Given this list of marker genes APCS, LOXL3, ATG9A, MIR140, HAVCR2, SLC4A2, IL13RA2, CEBPB, YPEL4, DPP4, GRN, CD200R1, SPN, IL33, FBXW7, LILRB3, SAMHD1, LGALS3, SERPING1, RUNX3, PRKAR1A, SFTPD, UBASH3A, LAX1, SCRIB, CRK, GLI3, MEFV, MYC, THY1, EMILIN1, LST1, C4BPA, TARM1, CXCL12, INHBA, HLA-E, CSNK1A1, BPI, HSPA8, PPT1, SLAMF1, TLR6, HOXA7, NCK1, TREX1, IL20RB, ABHD8, HFE, AURKB, ILDR2, RNF125, STAT6, DCST1, IHH, PLCL2, SNAI2, FCGR2B, MAPK3, NRARP, NR1D1, ZNF675, KLRD1, MIR130A, MIR149, BTNL2, TNFRSF21, DLG1 (discs large MAGUK scaffold protein 1), CD160, OTOP1, LGALS9B, TRIM32, CCL21, TSC22D3, HSPA9, SERPINB4, ABHD17A, MFHAS1, CD37, MIR17, AKT1, GREM1, FYN, IRF1, GPX1, TRIM21, PRKDC, IL12B, PLA2G2A, TSC22D1, CEBPA, C5, GRB2, LILRB4, HLA-A, ASCL2, DDT, UFD1, PARP1, CD300LF, BPIFB1 (NCBI Gene Id 92747), GPR17, MMP28, PKN1 (NCBI Gene Id 5585), CX3CR1, NPY, SMCR8, TSPAN6, PRNP, SPI1, RNF115, CD46, NLRC3, LGALS9C, NECTIN2, NECTIN4, PTGER4, APOD (NCBI Gene Id 347), RASSF5, GPR108, CCL2, PLK2, PARP14, MIR19B1, DTX1, HCK, RUNX1, APPL1, HLX, TGFB3, ACOD1, ARG1, USP18, PAG1, FBXO7, CD55, DUSP3, PADI2, BMP5, BANK1, NDFIP1, PPP6C, AMBP, CCL3, CD200, ZDHHC12, LAPTM5, WASL, IAPP, RNF39, ERBIN, SEC14L1, HMGB1, SELENOS (NCBI Gene Id 55829), ERBB2, LGALS9, SFRP1, ADIPOQ, LRRC17, RPS19, FGR, MDK, VSIG4 (NCBI Gene Id 11326), ZC3H8, ITPRIPL1 (ITPRIP like 1), PELI1, CASP3, GPR18, DLL1, IDO1 (indoleamine 2,3-dioxygenase 1), SLIT2, RAG2, MIR185, SOCS5, COL3A1, STAP1, GNRH1, LRFN5, GAL, OLFM4, LRRC32, DAPL1, TIGIT, IFNB1, TTLL12, TNFRSF11B, BMP4, MIF, TYROBP, CUL4A, MIR486-1, SH2D1A, IL2RA, TREM2, STAT5A (NCBI Gene Id 6776), AXL, DHX58, MIR19A (NCBI Gene Id 406979), RHBDD3 (NCBI Gene Id 25807), HLA-B, TICAM2, A2M, FGL1, GPR68, GPS2, NPY5R, TRIB1, C5AR2, LDLR, PTPN2, ERFE, LPXN, IRAK3, RIPOR2, LILRB1, MIA3, MIR27A (microRNA 27a), SYK (spleen associated tyrosine kinase), CPTP, CSK, CR1, SQSTM1, CD300A, PRDX2, SLAMF8, PIAS3, IL4I1, IL10, TGFB1, AHR (NCBI Gene Id 196), MIR222, PAWR, PLA2G2F, CD33, C9orf72, CNR2, STAT2, PSMA1, MIR302A, CUEDC2, DUSP1, MAFB, TMEM176A, CCL25, TMEM176B, RIOK3, ACP5, TBC1D10C, CLNK, SMAD7, ZC3H12A, BCL6, LYPLAL1, PYDC5, GATA2, TGFB2, SMPDL3A, RHBDF2, BTRC, KLRK1, PVR, HLA-G, SOX11, GPNMB, GPR137B, FCRL3, GCSAM, SLA2, BST2, MIR125B1, GPR137, NMI, KITLG, MIR181B1, LAG3, TMEM131L, MIR210, NCKAP1L, MIR6869, MIR181C, KLRC4-KLRK1 (KLRC4-KLRK1 readthrough), TNFAIP6, PYDC2, LTF, FBXL2, DDX39A, TAOK3, ITCH, CTLA4, HMGB3, ADA, ISG15, PYDC1, MNDA, FGL2, SPINK5, GBP1, AARS2, CD68, PCBP2, FER, CD96, LAMP2, IL31RA, TWSG1, MIR708, TRIM31, SIRT2, CD84, RAB7B, DNAJA3, TKFC, PDPK1, MILR1, PGLYRP1, CX3CL1, CR1L, NF1, PLCB1, GDF15, MIR105-1, UBQLN1, NLRC5 (NLR family CARD domain containing 5), PDCD1LG2, CNN2, HLA-DOA, OAS1, SOCS1, PSMB4, CDK6, FCER1G, MAPK14, DTX4, NLRP4, DRD2, DUSP22, TNFSF18, TNFAIP8L2, TNF, HMOX1, GPR55, BTLA, MIR24-1, PPARG, LILRA2, IFNA2, C4BPB, HLA-F, YES1, JAK3, IL4R, PTPRC, INHA, PRDM16, EIF4E2, SFN, ATG12, CD69, CD86, CEACAM1, IL7R, PIM1, CLDN18, NLRX1, ZDHHC18, CCN3, FN1, RIN3, ZBTB46, IL17D, VSIR, CD72, NLRP2B, IL2, CGAS, LRCH1, MIR20A, TAFA3, CD74 (NCBI Gene Id 972), FBN1, HLA-DRB1, WDR41, MIR146A, FAM76B, PPP3CB, TWIST1, SAMSN1 (SAM domain, SH3 domain and nuclear localization signals 1), MIR125A, DGKZ, CEP63, CNOT7, ATG5, PLA2G5, ADAR, SERPINB9, DAB2IP, CD80, IFI16, GNAS, TCTA, TLR4 (NCBI Gene Id 7099), MIR30B, CBFB, PLA2G2D, IFNL1, TMEM178A, TBX21, NR1H2, CD274, ADORA1, USP15, CBLB, CR2, MICOS10-NBL1 (NCBI Gene Id 100532736), TRAFD1, BTK, EPX, SUSD4, BCR, MARCHF5, ARG2, TRIM11, ZFPM1, NBL1, SOX9, DUSP10, KLRC1, OGT, ARRB2, INPP5D, CALCA, GIGYF2 (GRB10 interacting GYF protein 2), SYT11, ANGPT1 (NCBI Gene Id 284), LRRC14, ATM, CYP19A1, ALOX15 (arachidonate 15-lipoxygenase), ANXA1, LILRA4, MIR34A, ADGRF5, IL4, APOA2, MUL1, MAD1L1, PTPN11, PGLYRP3, CCL28, MARCHF7, MMP12, MIR21, INS (insulin), UFL1, FOXJ1, MKRN2, FCRLB (NCBI Gene Id 127943), CARD8, LYN, DLG5, VTCN1, IRF4, SRC, CLEC4G, RARA, PARP3, MIR223, NPLOC4, USP5, MIR200C, GLMN, TAPBPL, YTHDF2, FAM3A, PIK3R1 (NCBI Gene Id 5295), HLA-DOB, TNFSF4, PGLYRP2, FSTL3, TNFRSF14, PRG2, PLCG1, YWHAZ, SARM1, CDKN2A, CD22, CD59, IL27RA, LYAR, ZPBP2, TAX1BP1, TMBIM6, EZR, NLRP6, FOXP3, CLEC12A, KIR2DL4, ADORA2A, CTNNB1, TYRO3, ELF1, PVRIG, GPAM, PTPRS, PDCD1, SHH, MASP1, GRAMD4, TARBP2, F2RL1, TNFRSF13B, GPATCH3, SDC4, CTSG, ADTRP, CCR2, RC3H1, XCL1, LILRB2, SMPDL3B, MERTK, RABGEF1, SPSB3 (NCBI Gene Id 90864), TRIM27, BTN2A2, MIR200B, OTUD4, YWHAE, YTHDF3, PTPN6, BANF1, NR1H3, METTL3 (NCBI Gene Id 95719), CST7, SOCS6, THBS1, TOB2, PHPT1, MIR4691, ZNRF4, GPER1, TSPAN32, TRIM65, OAS3, MIR221, TNFAIP3, FURIN, PTPN22, USP38, LGALS1, MICA, PIBF1, UBASH3B, NFKBIL1, RC3H2 (ring finger and CCCH-type domains 2), MIR302E, QKI, PTPRJ (NCBI Gene Id 5795), CRTAM, C1QC, MIR128-1, SCGB1A1, SMIM30, CLEC12B, C1QBP, ENPP3, CACTIN, ZBTB7B, CARTPT, IRGM (NCBI Gene Id 345611), IL1RL1, ID2, TLR3, FOXF1, FADD, LGR4, APOA1, here is a description of the gene set: studied in species Homo sapiens Any process that stops, prevents, or reduces the frequency, rate, or extent of an immune system process. Human Gene Set: GOBP_NEGATIVE_REGULATION_OF_IMMUNE_SYSTEM_PROCESS